Given this list of marker genes NOD1, OAS2, IL17A, NOD2, PIK3R1, ABCC8, FZD5, TLR1, IL6, HLA-E, ARHGEF2, PTPRC, CCL3, DDT, ORM2, TLR4, IFNGR1, MIF, NFATC4, MAVS, BCL10, SYK, TGFB1, CARD9 (caspase recruitment domain family member 9), NRDC (nardilysin convertase), AGER, STAT3, CYBA, FCER1G, TWIST1, IL12B, PYCARD, FCGR1BP, HAVCR2, CD36, CD86, CCL19, MIR206, EPHB2, FCGR2B, MAPKAPK2, SELENOK, TLR3, LEP, AKAP12, TNFRSF8, TLR9, CLEC7A, FCGR2A, ISL1, FCGR1A, APP, RIGI, PLCG2, RIPK1, SETD4, MIR657, ADAM8, MIR27B, MMP8 (NCBI Gene Id 4317), SPHK2, MIR144, LPL, THBS1, OAS3, IL33, PTPN11, WNT5A (Wnt family member 5A), CD2, SPN, AZU1, CCR2, JAK2 (Janus kinase 2), IL1A, LILRA5, FADD, LRRK2, PSEN1, MYD88, CD14, HDAC2, OAS1, ADAM10, LY96, IFNG (NCBI Gene Id 3458), PTPRJ, CLU, IL23A, BTK, SASH3, FRMD8, IFIH1, CYBB, IL17F, ORM1, HMGB1, LBP, ARID5A, LILRA2, ARFGEF2, C1QTNF4, DHX9, TMEM106A, FCGR2C, HSPB1, PF4, TYROBP, LGALS9, TLR2, SPON2, RIPK2, TICAM1, ADAM17, FCGR3A, ZBTB20, TIRAP, here is a description of the gene set: Any process that activates or increases the frequency, rate or extent of tumor necrosis factor superfamily cytokine production. species: Homo sapiens Human Gene Set: GOBP_POSITIVE_REGULATION_OF_TUMOR_NECROSIS_FACTOR_SUPERFAMILY_CYTOKINE_PRODUCTION